The following is a description of a gene set: studied in species Homo sapiens Human Gene Set: chr12p13, and this is the list of marker genes: GNAI2P1, TPI1, CD4, RNU6-174P, KLRB1, TAS2R7, GDF3, KLRG1, TAS2R30, ENSG00000287928, RN7SL380P, P3H3, KLRC2, A2ML1-AS1, TEAD4, RNU6-590P, NINJ2-AS1, ENO2, CLEC6A, CLEC1B, ERC1, CRACR2A, ENSG00000299726, NANOGNB, SPSB2, RAD51AP1, HTR7P1, CLEC2B, KLRC4, LINC02443, USP5, LINC01559, TAS2R15P, TAPBPL, TAS2R64P, A2ML1-AS2, DDX12B, RAD52, VDAC2P2, IQSEC3-AS2, LINC00940, RIMKLB, PHB2, MFAP5, CDCA3, GPRC5A, KLRK1, WNT5B, RNU7-103P, PTPN6, ETV6, PTMAP9, ENSG00000278356, CLEC4D, ATN1, CHD4, LINC02367, C1R, OR7E148P, FBXL14, IQSEC3-AS1, THCAT155, FAM90A1, RPL13P5, ENSG00000255649, NCAPD2, SRP14P1, PRH2, HEBP1, RN7SKP161, A2ML1, LINC00942, CLEC12A-AS1, PRB4, RNU7-60P, GAPDH, PTMAP4, SNORA75, ITFG2-AS1, FGF6, TAS2R18P, CBX3P4, HSPD1P12, EMG1, ATF7IP, MIR3649, BORCS5, ATP5MFP5, A2MP1, OLR1 (NCBI Gene Id 4973), CD27, RN7SL391P, TNFRSF1A, FOXJ2, PRB2, RPL23AP66, RPS27P3, PIANP, RNU6-1315P, RNU6-318P, VAMP1, NPM1P7, NANOG, CLEC2D, PLBD1, GSG1, DDX11L8, WNK1, COPS7A, MRPS18CP4, MIR200C, MAGOHB, C1S, RPS3AP43, MIR1244-3, HSPA8P5 (heat shock protein family A (Hsp70) member 8 pseudogene 5), TEX52, HNRNPABP1 (NCBI Gene Id 390294), ENSG00000255746, CREBL2, ZNF705A, MLF2, VPS51P3, PZP, LPAR5, PEX5, FAM66C, A2M, APOBEC1, ENSG00000295726, TAS2R43, RNU6-275P, TULP3, KLRD1, TIGAR, LINC01252, KLRC4-KLRK1, MIR613, LINC02972, LPCAT3, DUSP16, RBP5, KLRA1P, ENSG00000252727, STX8P1, LINC02417, LINC02455, LINC02598, LTBR, LINC02449, FAM138D, PRMT8, ENPP7P5, KLRF2, CCND2 (NCBI Gene Id 894), KCNA5, TPT1P12, IQSEC3P1, CLECL1P (NCBI Gene Id 160365), CLEC4C, CLEC4A, HTR1DP1, C1RL, ENSG00000221611, LINC02470, PHC1, SCARNA12, RNU6-700P, NOP2, DPPA3, RPS4XP14, LINC02617 (NCBI Gene Id 113523642), IQSEC3, PARP11 (NCBI Gene Id 57197), RPL13AP24, OR7E140P, TSPAN9-IT1, KLRF1, RNU6-781P, TMEM52B, C3AR1, HIGD1AP8, GABARAPL1, NANOGP1, PTMS, RNA5SP353, GRIN2B, GNB3, HADHAP2, SLC6A12, CLSTN3, GPR19, DDX55P1, VAMP1-AS1, RPL21P136, TAS2R9, LINC00937, A2M-AS1, MIR1244-4, MANSC1, CACNA1C, FAM234B, CDKN1B, RPL23AP14, TAS2R50, MRPL51 (mitochondrial ribosomal protein L51), GPR162, NDUFA9, RPL31P10, CLEC9A, RNU6-491P, NECAP1, CD163L1, CLEC2A, TAS2R12P, LINC02366, CACNA1C-IT3, CD9, FERRY3, YBX3, TAS2R20, C1RL-AS1, OR7E149P, EMP1, SCARNA11, TAS2R19, SLC2A14, GCNAP1, TAS2R13, ADIPOR2, TAS2R8, BCL2L14, GCSHP4, MIR200CHG, DCP1B (NCBI Gene Id 196513), MIR141, DSTNP2, SMIM10L1, TSPAN9, SLC2A3, FGF23, GALNT8, KRT17P8, SLC25A39P2, HNRNPA1P34, B4GALNT3, HSPE1P12 (heat shock protein family E (Hsp10) member 1 pseudogene 12), EIF2S3B, ALG1L10P, ACSM4, CACNA1C-AS4, PRB1, ZNF384, LINC02446, ACRBP, OTUD4P1, LINC00612, RPL21P100, M6PR, KLRC1 (NCBI Gene Id 3821), RNU6-485P, LINC02371, RHNO1, KCNA6, AKAP3, KLRK1-AS1, KLRC3, CD69, PLBD1-AS1, CACNA1C-AS3, PARP11-AS1, RPL13AP20, PLEKHG6, GOT2P3, GPRC5D, APOLD1, DEFB109F, ING4, FKBP4, ITFG2, LRRC23, CCDC77, RN7SKP134 (NCBI Gene Id 106479154), CACNA1C-IT1, LINC00987, SCNN1A, CLEC1A, RNU7-1, ENSG00000305396, LAG3, LINC02390, TAS2R14, LRP6, GAPDH-DT, POU5F1P3, TAS2R46, RN7SL69P, TAS2R42, WASH8P, RPSAP51, PRB3, ENSG00000295827, RPL30P11, PRR4, SUPT4H1P2, CLEC12A, GABARAPL1-AS1, GAPDHP31, IFFO1, RNU4ATAC16P, NINJ2, NIFKP3, CD163, BTG1P1, CLEC7A, DDX47, MIR614, FAM86FP, ENSG00000249695, SCARNA10, SLC6A13, VWF, DYRK4, RPL15P17, LINC02827, LRTM2, CLEC4E, KCNA1, NRIP2, STYK1, PRH1, TAS2R31, ENSG00000299754, SLC6A12-AS1, LOH12CR2, RNU6-545P, TAS2R63P, GAU1, DDX12P, CACNA2D4, C12orf57, ANO2, CCND2-AS1, FOXM1, AICDA, NTF3 (neurotrophin 3), CLEC12B, TAS2R10, GPRC5D-AS1, ENSG00000284634, KDM5A, RN7SKP162, ENSG00000256969, CD27-AS1